Given this list of marker genes Smurf1, Marveld3, Arf4, Nrp1, Wdr26, Primpol, Brk1, Larp4b, Prrt3, Pnn, Ercc6l, Set, Dlgap1, Tecpr2, Wnk3, Nfat5, Rtl5, Mylk4, Sox6, Btaf1, Gtf2i, Bclaf3, Cnot4, Ctnnal1, Fbxl17, Vmn1r45, Ddi2, Glcci1, Aak1, Nr6a1, Dcaf17, Fam135a, Aebp2, Smad2, Ing3, Sectm1a, Zfp606, Tut4, Rnf130, Dock4, P2rx3, Spcs3, Sike1, Phldb1, Kpna4, Cpd, H13, Slc39a9, Rbm3, Psmc6, Steap2, Snx16, Ogt, Ccdc25, Ermn, Zfp292, Prpf8, Ntrk2, Desi2, Dtymk, Chst11, Arhgap26, Fancl, Ablim1, Ino80, Tom1l2, Bmf, Supt4a, Phf6, Tox4, Dppa4, Car7, Tmem47, Fbxl7, Fam210b, Rgp1, Gm3985, Sele, Egflam, Scrt2, Klhl2, Nup210, Rcor1, Scrn1, Cort, Pllp, Tnfrsf19, Plppr5, Tcf23, Rbbp6, here is a description of the gene set: from publication Chen Y, Wang X (PMID 31504780) studied in species Mus musculus Mouse Gene Set: MIR_93_3P Genes predicted to be targets of miRBase v22 microRNA mmu_miR_93_3p in miRDB v6.0 with MirTarget v4 prediction scores > 80 (high confidence targets).